Given this list of marker genes PRLR, PBXIP1, ST6GALNAC2, TMEM72, FZD4, LGALS3BP, PCOLCE2, FXYD1, VWA3A, FOLR1, ADH1A, ABCA4, EPHX1, COL9A3, CPED1, LBP, CLDN2, ELOVL7, FHAD1, FANCM, PERP, MROH7, LRP10 (NCBI Gene Id 26020), INMT, COL8A2, GGH, RSPH9, GC, DNALI1, ITGB5 (NCBI Gene Id 3693), TXNIP, F13A1 (coagulation factor XIII A chain), SPATA17, SGMS2, SLC6A20, ECRG4 (NCBI Gene Id 84417), NOTCH2, PCOLCE, CTSC, LEPR, TBC1D9, MGP, SYNE2, STRA6, SLC26A11, CDH3, KCNE2, ATP6V0E1, SLC24A5, HEMK1, KIF9, TTR, KDR, MXRA8, ACAA2, COL8A1, DUSP22, LDC1P, TMPRSS11A, SPINT2, ACE, RBP1, EZR, EPCIP, NEK11, CSRP2, CLDN1, ACACB, PLTP, LUM, CCND3, STEAP2, KLHDC7A, WFDC2, KL, CFH, NXN, TTC21A, MYO7A, FADS1, SOSTDC1, SULF1, ODAD1, TPSD1, TGFBI, CALML4 (NCBI Gene Id 91860), SLCO1C1, PRR32, PGPEP1 (NCBI Gene Id 83542), ACAD8, SLC39A12, MSX1, EFS, OTX2, CPQ (NCBI Gene Id 51670), TRPV4, RBM47 (NCBI Gene Id 54502), SLC4A5, F5, TCN2, TMEM237, NID2, CFAP44, RNASET2, CAB39L, here is a description of the gene set: Human Gene Set: LEIN_CHOROID_PLEXUS_MARKERS studied in species Mus musculus from publication Lein ES, Hawrylycz MJ, Ao N, Ayres M, Bensinger A, Bernard A, Boe AF, Boguski MS, Brockway KS, Byrnes EJ, Chen L, Chen L, Chen TM, Chin MC, Chong J, Crook BE, Czaplinska A, Dang CN, Datta S, Dee NR, Desaki AL, Desta T, Diep E, Dolbeare TA, Donelan MJ, Dong HW, Dougherty JG, Duncan BJ, Ebbert AJ, Eichele G, Estin LK, Faber C, Facer BA, Fields R, Fischer SR, Fliss TP, Frensley C, Gates SN, Glattfelder KJ, Halverson KR, Hart MR, Hohmann JG, Howell MP, Jeung DP, Johnson RA, Karr PT, Kawal R, Kidney JM, Knapik RH, Kuan CL, Lake JH, Laramee AR, Larsen KD, Lau C, Lemon TA, Liang AJ, Liu Y, Luong LT, Michaels J, Morgan JJ, Morgan RJ, Mortrud MT, Mosqueda NF, Ng LL, Ng R, Orta GJ, Overly CC, Pak TH, Parry SE, Pathak SD, Pearson OC, Puchalski RB, Riley ZL, Rockett HR, Rowland SA, Royall JJ, Ruiz MJ, Sarno NR, Schaffnit K, Shapovalova NV, Sivisay T, Slaughterbeck CR, Smith SC, Smith KA, Smith BI, Sodt AJ, Stewart NN, Stumpf KR, Sunkin SM, Sutram M, Tam A, Teemer CD, Thaller C, Thompson CL, Varnam LR, Visel A, Whitlock RM, Wohnoutka PE, Wolkey CK, Wong VY, Wood M, Yaylaoglu MB, Young RC, Youngstrom BL, Yuan XF, Zhang B, Zwingman TA, Jones AR (PMID 17151600) Genes enriched in choroid plexus cells in the brain identified through correlation-based searches seeded with the choroid plexus cell-type specific gene expression patterns. Molecular approaches to understanding the functional circuitry of the nervous system promise new insights into the relationship between genes, brain and behaviour. The cellular diversity of the brain necessitates a cellular resolution approach towards understanding the functional genomics of the nervous system. We describe here an anatomically comprehensive digital atlas containing the expression patterns of approximately genes in the adult mouse brain. Data were generated using automated high-throughput procedures for in situ hybridization and data acquisition, and are publicly accessible online. Newly developed image-based informatics tools allow global genome-scale structural analysis and cross-correlation, as well as identification of regionally enriched genes. Unbiased fine-resolution analysis has identified highly specific cellular markers as well as extensive evidence of cellular heterogeneity not evident in classical neuroanatomical atlases. This highly standardized atlas provides an open, primary data resource for a wide variety of further studies concerning brain organization and function.